The following is a description of a gene set: from publication Yevshin I, Sharipov R, Kolmykov S, Kondrakhin Y, Kolpakov F (PMID 30445619) Mouse Gene Set: GCM2_TARGET_GENES Genes containing one or more binding sites for (Gcm2) in their promoter regions (TSS -1000,+100 bp) as identified by GTRD version 20.06 ChIP-seq harmonization. studied in species Mus musculus, and this is the list of marker genes: Atp5pb, Scn5a, Iqgap1, Vmn2r-ps19, Zfp689, Emg1, Pax5, Tph2, Morn2, Kdm3a, Lsm3, Pofut1, Gfi1b, Dis3l, Tsen15, Tmem198, Hagh, Mir6935, Cpne9, Ikbkb, Gas2l1, Ckap5, Aip, Zfp646, Dcaf8, Setmar, Car7, Rbm25, Fcgrt, Chpf, Zfp784 (NCBI Gene Id 654801), Strbp, Wdr77, Bcl2l13, Capg, Snhg7os, Sfpq, Glg1, Nyap2 (NCBI Gene Id 241134), Psmd14, Ube2k, Sike1 (NCBI Gene Id 99724), Synj1, Bcan, Pnrc2, Lrp3, Mir291a, Aak1, Rapgef1, 1700048O20Rik, F13b, Hnrnph1, Gm33142, Coq9, Tcf7l1, Atg4c, Ddx39a, Asns, Usb1, Pus3, Trmt44, Brpf1, Map2k2, Scn8a, Gm16099, Suv39h2, Wdr17, Ppp2r5a, Wdr12, Furin, Rbsn, Hnrnpa0, Snapc2, Crb2, Pias3, Ubr2, Gm14261, Sec14l5, Timm50, Nufip2, Snrpg, Gtpbp8, Mrps35, Pgm2, Asphd1, Dnmt3a, Snhg6, Adam6b, Gria2, Prm1, Rnf7, Pard3, D030047H15Rik, Mir9-3hg, Nphs1, Wdr1, Srsf1, mt-Te, Zfas1, Trp53inp1 (NCBI Gene Id 72576), Pdcd2l (programmed cell death 2-like), 2610005L07Rik, Vgf, Zfp882, Ankrd52, Hjurp, Dars2, Cwc22, Ogdh, Airim, Zc3h18, Ptpa, Bola1, Safb2, Yif1a, Ammecr1l, Ankrd16, Dclre1b, Slc3a2, Smarca5-ps, Wdr62, Actb, Smim27, Paxip1, Ssbp1, Nedd8, Txnrd1, Sdc1, Rnf44, Cxcl12, Sqstm1, Os9, Gatm, Ago1, Scamp5, Ppp1r13l, Hspa8, Zdhhc21, Spata1, Speer4cos, Snapin, Svop, Vps26a, Dlg4, Cimap2, Thrap3, Brd2, Gm3248, Dnajc9, Trir, 5430416N02Rik, Kbtbd2, Gm12492, Rnf215, Gm22863, Gm16283, Snx24, Inpp4a, Nop56, Stx1a, Mterf2, Gm13136, Zfp866, Sall4 (NCBI Gene Id 99377), Bola3, Dmxl1, Eif3e, C030034I22Rik, Cog4, Rpl11, Rps6kc1, Top3b, Mgat4b, Mrrf, Tcp1, Mir6236, Gm13077, Nrxn1, Rptor, Gm15526, Gm25045, Nr2c2, Hnf1aos1, Mir8112 (microRNA 8112), Dnaja2, Gm22107, D830025C05Rik, Fbxl19, Srsf9, Fam163b, Gm17916 (NCBI Gene Id 100416102), Dner, A230060F14Rik, H2-T11-ps, Slc25a27, Ubxn8, 6820408C15Rik, Nr2e1, Dip2a, Zscan29, Mtmr10, Gm15881, Cbfa2t2, Trmo, Cryzl1, Chka, Atp5f1b, Asic3, Dda1 (DET1 and DDB1 associated 1), Lrtm2, Stxbp5l, Skp1, Nup153, Rbmxl2, Zfp451, Mybbp1a, Cxcl1, Appbp2os (NCBI Gene Id 654810), Nell1, Gm6483, Rhoa, 2510016D11Rik, Slfn5, Letmd1, Tcta, Snord49b, Fbh1, Zfp143, Emc8, Phc1, Snora26, Trmt10c, Mrpl48, Odf2l, Gm25855, Chmp3 (charged multivesicular body protein 3), Mrps15, Bop1, Luc7l, Sez6l2, Daxx, Ccnq, Dysf, Kcns2, Cntnap5c (contactin associated protein-like 5C), Nav2, Adgrb3, Mir1932, Gm24016, Cacng2, Ctdsp2, Zfp617, Gm23437, AA386476, Jagn1, Scg5, Fam120a, Mcrs1, H1f4, Lgr5, Gtf3c4, Gm26766, mt-Cytb, Trpm7, Ppme1, Cacng3, Akirin2, Gm16077, Amer3 (APC membrane recruitment 3), Rnf38, Rfc4, Thumpd3, Amfr, 4930590L20Rik, Tmem179, Leng8, Nrn1, Marchf4, Dynlt1b (NCBI Gene Id 21648), Tpm3, Gdap1, Hk2, Zscan2, Taf1d, Cyp4f18, Epb41l4aos, Lrp11, Rex2, Cdkn1b, Ndufa5, Rpl30, Rbfox3, Barhl1 (NCBI Gene Id 54422), Rnu11, Car3, Mbd3, Cir1, Slc5a11, Gm22711, Gm5046, Scn2a, Osmr, Dnajc17, Mapk8ip2, Atp5f1a (NCBI Gene Id 52533), Or10aa1, Gpd2, Madd, Actl6b, Nrbp1, Hs3st2, Gm24494, Otub1, Gm11149, Nudt19, Tbkbp1, Zfp110, Zfp442, Sumo2, Anapc4 (anaphase promoting complex subunit 4), Gm43391, 9430015G10Rik, Phc2, Diablo, Bsx, Dhx38, Elf1, Mir7090, Myoz1, Rpgrip1l, Ccdc25, Cdc34, 5031425E22Rik, Ufc1, Cox7c, Syncrip, Bcl2l1, Ccdc157, Alg5, Rsrc1, Inpp5f, Gm26419, Gps2, Brd7, Hsf1, Ctu2, Dmrta1, Sephs2, Cmc2, Phkb, H3c2, Cops6, Gm8357, Mettl25b, Cebpg, Adgrb1, A330035P11Rik, Eif2ak3, Hes1, Safb, Cdh1, Naa15, Mrap, Myl4, Mipep, 4930412F09Rik, Hmgn2, Wdr41, Cep95, Gm20522, Rpgrip1, Gm26205, Gm4131, Eif4ebp1, Asah1, Dlgap1, Sptbn4, Pclo, Sf1, Rc3h2, BC048644, Gm43568, Fiz1, Large1, Prm2, Cyb5rl, Zfp668, Gm13161, Glt8d1, 0610009L18Rik, Pdgfc, C2cd3, Znrf2, Anapc13, 1700122E12Rik, Ints5, Ctcf, Noa1, Gm13355, Gins1, mt-Tt, Fstl5, Ddx46, Sumf1, Ctnnb1, Tmprss13, Nfu1 (NFU1 iron-sulfur cluster scaffold), Ncl, Mtmr2, Esm1, Ktn1, Mcm6, 1810012K16Rik, Rab3c, Pcmtd1, Ctxn2, Gm26345, Map2, Gm27003, Cdca3, Tcf25, Nol10, Casp2, Bicdl1, Rassf7, Prdx1, Cdca8, Ccdc92b, Bicd1, Slc25a28, H6pd, Mtpn, 4933433G15Rik, Tmem229b, Gm9918, Polr3f, Foxn4, Gm13163, Nudt16l1, H3f3a, Nppb, Cntnap2 (NCBI Gene Id 66797), Chchd4 (NCBI Gene Id 72170), Dusp16, Ints6, Polr2b, Immt, Kif11, Bdnf, Smpd4, Kpna4, Plcd4, Uck2, Gpatch1, Ywhag, Chchd3, Gjd2os, Gm6903, Krcc1, Tpm1, Plekha7, Mir290b, Naxd, Grid2ip, Tug1, Tmpo, Meis3, Atxn2l, Nfkbiz, Sfi1, 5930411N13Rik, Fa2h, Fto, Rab7, Atxn7l1, Kat7, Uhmk1, Eif4a3, Xpc, Pcsk1, Esrp2, Nefm, Tmem143, 1700084C06Rik, Ninl, H2bc21, Slc15a4, Raf1, Sez6, Eid2b, Cycs, Cand1, Klhl28, Krt10, 4930478K11Rik, Tlk2, Sp3, BC049715, Eef1a1, Btg1b, Glrx3, Tap1, Mob3c, Celsr3, 6820431F20Rik, Isg20l2, Ttc9b, Entpd5, Npas1, Ska2, Mrpl18 (NCBI Gene Id 98071), Farsa, Tnip3, Hnrnpk, Fnbp4, Cyc1, Kcnk12, Gnas, Itsn1, Nusap1, Cnep1r1, Mrps7, Acsl6, Nars1, Hnrnpd, Vwa3b, 3110070M22Rik, Snrk, Or4c58, Gm32950, Gng4, Ffar2, Kdm5a, Gm24453, St8sia3, Or6e1, 1700030K09Rik, Ddx5, 4933408J17Rik, Usf1, Tango2, Snora17, Stag1, Grin1, Chic1, Snhg5, Cep250, 1700125G22Rik, Jkamp, Slc25a36, Sec23a, Rbm39, Crtc1, Copg2, Gad2, Dcun1d4, Ddx25, Mir212, Ttc3, Gm11399, Actr2, Akt1s1, Eif4g2, Sntg1, Esrrg, Lrrc24, Kansl3, Zbtb7a, Olfm3, Or10a3b, AA474408, Atp6v1b2, Rpl18a (ribosomal protein L18A), A930005N03Rik, Bap1, Abcc5, Lypla1, Kcnh6, Eef1d, Atf2, Smchd1 (SMC hinge domain containing 1), Rabggtb, Terf2, Eif3i, Sema5b, Gm4909, Rps27l, Gm16204, Actl6a, Gm2427, Brd4, Rab11bos1, Rdh10, Psmb9, Ttc13, Gm5250, Gpr19, Bet1, Xkr6, AA467197 (expressed sequence AA467197), 1700074A21Rik, Atp2a2 (ATPase, Ca++ transporting, cardiac muscle, slow twitch 2), 4930554H23Rik, Sec13, Slc8a2, Tubgcp4, Coro1c (NCBI Gene Id 23790), Npdc1, Col9a2, Nwd1, Hexim2, Gpr6, Hes2, Tm9sf2, Rbm33, Lbhd1, Ptprn2, Uggt1, Prlhr, Drd2, Cit, Lockd, Sdha, Ppp2cb, Amn1, Syngr4, Plekhh3 (pleckstrin homology domain containing, family H (with MyTH4 domain) member 3), B230112G18Rik, Gm24985, Gm15320, Tmem43, Luc7l2, Prmt7, Car2, Ogdhl, Akain1, Unc13a, 4931406C07Rik, Spcs1, Zfp846, Pdlim3, Gm5577, Dancr, Cog3, Morc2a, Zfyve19, Lhfpl5, Rpl15, 5430402O13Rik, Rpl7, Slc39a3, Katna1, Spata31e2, Car10, Snord2, Cenpn (NCBI Gene Id 72155), Dip2c, Kin, Bub1, Tax1bp1, Slc17a6, Scap, Scg2, Gm9884, Glod4, Gm35025, Dnaja3, Lrch3, Kmt5b, A730020E08Rik, Six6, Hdhd5, Syn1, Gpr153, Pold2, Grm1, Ctdp1, Gm10545, Vpreb1a, Brwd1, Glb1l, Fahd1, Aadacl4, Tsen54, Ghsr, Mcph1, Exosc8, Trat1, Rell2, Zfp672, Idi1, Malsu1, Rab8a, Cyp39a1, Trpc4ap, Gm11520, Gm29856, Tfcp2l1, Gm15912, Kalrn, Trmt13, Wars2, Ap5s1, E2f2, Tigd5, Dync2i2, Hpca, Gipc1, Calr, Gpr146, Ccdc77, 1700052K11Rik, Gm22479, Gm11355 (NCBI Gene Id 100040957), Pick1, Nkiras1, Cyb5b, Hyou1, Ccser1, 2810002D19Rik, Schip1 (NCBI Gene Id 30953), Capns1, Pde7a, Ptprd, Syp, Gnb4, Btbd19, Nfat5, Omg, Mir5122 (NCBI Gene Id 100628620), Tardbp, Nup205, Hoxa1, Zfp282, Pdzd7, Mon1b, Gsx1, Zc3h4, Sdhaf3, Htr5a, Taok3, 1810019D21Rik, Ap4b1, Hsp90ab1, Cntnap5b, Pou4f3, Ankle2, Mir291b, Zfp771, Nanog, Slc25a12, Tent4b, Agrp, Snora57, Ajap1, Rbm18, Chic2, Spopl, Wbp11, Tpp2, Kif5b, Zcchc14, Ncdn, Klhdc8b, Casc3, Lrrcc1, Nell2, Stk16, Xpo6, Cdk5rap1, Gm14966, Gpr158, Eefsec, Ciapin1, Ncapd2 (NCBI Gene Id 72814), Snx4, Pcyox1 (NCBI Gene Id 66881), Urgcp, Trpm8, Dnaaf9, Ckmt1, Celf6, Zdhhc5, Gm13162, Cyb5d1, Sec11a, Gm12290, Gm37450, Unc80, Ifi30, 1700047K16Rik, 4930455B14Rik, Plcg1, Cd200r1, Abl2 (NCBI Gene Id 98214), Neurod4, Khsrp, Ei24, Smim5, Med28, Cyp51, Klhl9, Atp6v1f, Bclaf3, Snord45c, Rpl6, Gm26614, Sirt4, Gm22122, Snora7a, Srrm3, Gm15564, Ube2i, Pcsk2os1, A130014A01Rik, mt-Nd6, Tssk6, B230217O12Rik, Pik3ca, Kcnc1 (potassium voltage gated channel, Shaw-related subfamily, member 1), Sfxn4, Nbas, Rpl12, Gm25894, Tmem267, Gm25878, Vip, Ppm1l, Usp48, Dach1, Cadps, Polr3c, Osbp2, Hrh3, Kcnb1, Adprs, Xpnpep3, Nfyc, Ezh2, Lgr6, Gale, Tatdn2, Sh3bp5l, Mrpl19, Gm29257, Cdk5r1, Zswim4 (zinc finger SWIM-type containing 4), Pgls, Pura, 2500002B13Rik, Src, Scrt1, C030005K15Rik, H2-Ob, Nrde2, Tex15, Rxfp3, Thoc3, Zfp958, Oprm1, Card19, Mir8109 (microRNA 8109), Avl9, I830134H01Rik, Irf2bp2, Tmem234, A930029G22Rik, P4hb, 4930583K01Rik, Copg1, Terf2ip, Fdft1, Tpra1, Tmem128, Rexo1, Gm1070, Mir7075, Cpne4, 2810013P06Rik, Tigd3, Atp6v0a1, Dtd2, Dyrk1a, Mfsd11, Aars1, Zc3hav1, Dcp1b, Fancd2, Chrnb2, Slc9c1, Cox4i1, Ing2, Rpl22l1, Miga2, Trpc7, Wtap, Zfp532, Eri3, Nol4l, Traf3ip2, Fbxo7, Ifrd1, Gm23405, Ptk2b, Ccdc71, Iqsec1 (NCBI Gene Id 79407), Snord49a, Cul9, Acp7, Caprin1, Ywhah, Ap2a1, Alyref2, Tmem134, St3gal2, Duxf1, Ramp2, Zwilch, Gm19744, Gm17690, Nxph1, Pex5l, Grcc10, Cpxm2, 1700086D15Rik, Adcyap1, Gm20404, Zfp579, Syngr1, Rab11fip1, Srsf2, Ncam2, Eogt, Rps5, Reps1, Ubp1, Spo11, Mfsd14a, Arv1, Ucn, Pou2f3, Dnah7a, Phb2, Tfrc, Gm31693, Tpt1, Atp5f1c, Ube2d-ps, Rnf115, Eif3d, Vwc2l, Pfkp, Zfp661, Usp1, Rab11fip4os2, Cdk2ap2, Mtarc2 (NCBI Gene Id 67247), Glra2, Mtag2, Fbxo21, Paqr4, Eif4a2, A830018L16Rik, Smim7, Zfx, Gm13034, H1f10, Brd3, Shank1, Mir132, Hkdc1, Rplp0, Cplx3, Trappc2b, Auh, Fmr1, Spc25, Cep63, Cep44, Glra1, Snora24, Pgbd5, Onecut2, Qrich1, Emc3, Srsf6, Gm29443, Mapk8ip1, Setd6, Slc9a1, Acvr1, Wrap53, Api5, A630095N17Rik, Carm1 (NCBI Gene Id 59035), Sap30, Usp53, 1700101I19Rik, Gm17344, Kcnt1, 1700120C14Rik, Tusc2, Slc25a35, Gm14125, Triap1, Gm4285, Ankhd1, Zdhhc18, Sarm1, Gm23639 (predicted gene, 23639), Fads1, Aggf1, Mfn1, Nr6a1, Nrip3, Syt14, Ppm1e, 2010110K18Rik, Gm15645, Crip2, Rmi1, Rp9, Psd, Tmem106b (NCBI Gene Id 76086), Ilrun, Prpf38b, Phlda3, C130036L24Rik (RIKEN cDNA C130036L24 gene), Mthfsl, Mmaa, Coil, Slc35a3, Kcnk3, Fastk, Dnajc6, H2-T23, Gm23181, Iba57, Dus2, BC025920, Tmem14a, Bcl3, Cenpl, Icmt, Fis1, Calr3, St13, Gm26885, Dvl3, Lamp5, Gt(ROSA)26Sor, Zfp652os, Phaf1 (NCBI Gene Id 338512), Cnrip1, Nptxr, Nhsl3, Scn3b, Gm27021, Calb1, Gng5, Rgs7, Lrsam1, 2010110E17Rik, Snx1, Bsn, Hotairm1, Ap1g1, Wasf1, Rnf10, Syndig1l, Krt86, Tbc1d9, Phf7, Lpcat3, Usp46, Ccnb1, Swsap1, Dstn, Rundc3a, Scg3, Mapk11, Tyw5, Hspe1 (NCBI Gene Id 15528), Lypla2, Fam135a, A530083I20Rik, Or4k43-ps1, Mdk, Gm2453, Gadd45a, Ces1d, Mrpl12 (NCBI Gene Id 69758), Atxn2, Cyb5r4, Atf5, Uba52, Ubtd1, Acrbp, Iqca1, Foxp4, Slco5a1, Rxylt1, Snord14a, Prune2, Gm10710, Gm26684, Rpl32, B230354K17Rik, Rab39, Anapc10, Vmp1, Uqcrc1, D630003M21Rik, Msmb, Gm16208, Usp38, Champ1, Setd5, Cartpt, Tbc1d14, Gm40414, Fbxw8, Tmem154, Prdx2, Vegfa, Tmem120a, Gm26590, Ctbp1, Fbll1, Erc1, Nudcd1, Ift27, Snord118, Tex2, Mir1938, Smarce1 (NCBI Gene Id 74752), Casd1, Rps20, 1110018N20Rik, Smim14, Cnga3, Ank2, Zfp963, Tmed7, Gprin1, Dhps, Zmym4, Tial1, Trrap, Pdss2, Mapk6, Znrf1, Sf3b4, Or1i2, Cntnap1, Rnf166, Mrpl58, Nrxn2, Gm11973, Cdc40, Abcb6, Sptbn5, Cbfb, Kmt5c, Acd, Dhx29, Phf23, Msr1, Elovl2, Pde4d, 1810009A15Rik, E130317F20Rik, Gm15420, Septin4, Tppp, Abhd10, Ndufa12, Naa38, Gm24452, Dyrk1b, Celf3, Fxr1, Polg2, Dusp2, Gm13135, Lap3, Crls1, Frmd5, Catip, Tmem40, Ppm1d, Atn1, Htr1a, Camsap1, Gmpr2, Rab30, Mlkl, Arl8b, Sub1, Actn2, Usp5, Rrp36, Tsr3, Caskin2, Lnpk, Mtx2, Rps10, Nacad, Ubc, Pbld2, Eef1akmt2, Lamc3 (laminin gamma 3), Rock2, Marchf2, Gm27217, Fam32a, Slirp, Pcif1, Rnaseh2a, Nfe2l1, Rbm4b, 5330438D12Rik (RIKEN cDNA 5330438D12 gene), Wdr18, Hhatl, Snord59a, Mir292, Fat1, Mrpl51, Hmgb2, Vezf1, Znfx1, Nudc, Zfp524, Phrf1, Mir2139, Lhx3, Dynll2, Rnu7, Crebl2, Yy1, Ddx6, 5330439K02Rik, Pomc, Fgfr1, Gcat, Slc7a6os, Klhdc4, Smpd3, Actg1, AU040320, 4632427E13Rik, Fbxo8, Unc79, Heatr6, Birc6, Gm11592, Zmynd11, Matr3, Zfp30, Akr1b1, Ganc, Gm7008, Cntnap5a, Rph3a, Abr, Stx6, Agpat3, Sntb2, Hdhd2, Ccl25, Spire2, Txnl4b, Ddx31, Grm2, Csnk1d, Mir7b, Disp2, Nelfe, Tfdp1, Eef2k, Tmem222, Nabp2